Given this list of marker genes CHRNA4, P2RX4, CHRNA7, CHRNE, CHRNB3, GLRA2, P2RX7, P2RX3, CHRNB1, CHRNB2, CHRNA2, GLRA3, P2RX1, GLRA1, CHRNA3, here is a description of the gene set: Genes in the cancer module 267. species: Homo sapiens Human Gene Set: MODULE_267